Given this list of marker genes IFT88, WNT4, FGF10, IRX2, ADIPOQ, ID3, NID1, SIX4, PODXL, LZTS2, KANK2, LRP4, SMAD3, LGR4, PDGFD, EDNRB, TRAF3IP2, PKD2, HNF1A, BCL2L11, NPHS2, GATA3, VANGL2, IFT20, SALL1, HEYL, HS3ST3B1, FOXC1, CDKN1C, WNT5A, RARA, WNT6, PPP3CA, SDC4 (syndecan 4), BICC1, COMT, ANGPT2, KCNJ8, OSR1, IL6R (NCBI Gene Id 3570), C1orf54, RBP4, FGF1, SERPINB7, FGF8, FADD, HELLS, HOXA11, WFS1, ROBO2, DLG5, GFRA1, AQP11 (NCBI Gene Id 282679), NUP160, SLC34A1, C1GALT1, ACE, ADAMTS6, APH1A, AGT, BMP4, DDC, BMI1, AQP2, LAMA5, GDF6, AP1B1 (adaptor related protein complex 1 subunit beta 1), ALDH1A2, PRDM1, JMJD6, NIPBL, WNT2B, PAX2, POU3F3, EMX2, ERBB4, SFRP1, NKX3-1, DTNBP1, SMAD7, LIN28A, MTSS1, RHOA, PROM1, LRRK2, SLC22A1, KIF26B, SMAD4, GCNT1, SIX1, AMPD2, FOXD1, NF1, ACAT1, EDN1, TSC1, SNX17, OVOL1, HS3ST3A1, CYP4A11, SLC22A6, CTSH (cathepsin H), TNS2, IQGAP1, PKD1, MYC, HES5, FGF2, WNT1, CD34, GCNT3, NFIA, DCHS2, BMP7, ASXL1, NPHS1, PRICKLE1 (NCBI Gene Id 144165), GPR4, ANGPT1, PLXND1, TFAP2A, PYGO1, DYNC2H1, HS2ST1, AKR1B1, NOTCH3, STRA6, SMAD5, ZBTB14, CNTRL, CEP290, GDF11, SERPINF1, KLHL3, EDNRA, NPNT, LAMB2, PTK7, SMO, TMEM59L, BCL2, NOG, NRP1, PDGFRA, LRP2, MYOCD (NCBI Gene Id 93649), SHH, NOTCH2, PAX8, PBX1, ILK, SULF2, SLIT2, AGTR2, BMPER, IFT27, CITED1, WWTR1, SOX4, GLI2, MYO1E, APAF1, VEGFA, MAGI2, TREX1, INVS, DACT2, NLE1, PKHD1, LGR5, PDGFA, FOXJ1, DLG1, ASS1, CYP26A1, TP73, MAGED1, FOXF1 (forkhead box F1), SULF1, MME, PDGFB, KCNJ1, PRKX, HAS2, HOXD11, SEC61A1, ENPEP, AP2B1, RARB, ZBTB16, STAT1, ITGA3, PDGFRB, ADAMTS16, BAG6, EGR1, NUP107, EPHA7, GLIS2, NUP133, ACTA2, GPC3, FRAS1, ITGA8, AGTR1, BAX, TIPARP, TBC1D32, FLCN, SOX17, BMP2, CAT (catalase), SMAD1, CER1, ODC1 (ornithine decarboxylase 1), PROX1, ARID5B, SOX8, CTNNBIP1, HYAL2, YAP1, PYGO2, SPRY1, UMOD (NCBI Gene Id 7369), PTCH1, SMAD6, CRLF1, TBX18, IRX3, COL4A4, ARL3, SOX9, CD24, NUP85, CALB1 (calbindin 1), RET, TGFB2, GLI3 (NCBI Gene Id 2737), SOX11, HES1, CFLAR, SIM1, MMP17, NDUFS6, HPGD, MPST, RDH10, LIF, FREM2, PECAM1, SIX2, BLOC1S6, REN, TCF21, TGFBR1, BASP1, KLF15, DLL1, PCSK9, CENPF, MEF2C, CC2D2A, IRX1 (iroquois homeobox 1), EXT1, CTNNB1, EZH2, CUL3, COL4A3, EFNB2, WNT7B, HOXB7, LHX1, FBN1, ADAMTS1, TGFB1, GREM1 (NCBI Gene Id 7947), PTPRO, CD2AP, PCSK5, COL4A1, ARG2, EPHA4, WNK4, PTCD2, CYP26B1, BMP6, ZNG1A, WDPCP, BMP10, ACVR2B, NPHP3, JAG1, HNF1B, MIR125A, HOXC11, SGPL1, ITGB3, AMER1, UPK3A, FGFR2, FGFR1 (fibroblast growth factor receptor 1), EPCAM, WNT9B, TACSTD2, AQP1, GZF1, MMP9, RPGRIP1L, NOTCH1, RRM2B, TTC8, GDNF, WNT11, ZMPSTE24, PLCE1, ID2, EYA1, GCNT4, GREB1L, KIRREL3, DCHS1, WT1, ANKS6, OSR2, AHI1, SMAD2, CYP4A22, CASP9, HMGCS2, IFT25, TFAP2B, TEK, MPV17, FOXC2, TRAF3IP1, here is a description of the gene set: studied in species Homo sapiens The process whose specific outcome is the progression of the renal system over time, from its formation to the mature structure. The renal system maintains fluid balance and contributes to electrolyte balance, acid/base balance, and disposal of nitrogenous waste products. In humans, the renal system comprises a pair of kidneys, a pair of ureters, urinary bladder, urethra, sphincter muscle and associated blood vessels. Human Gene Set: GOBP_RENAL_SYSTEM_DEVELOPMENT